The following is a description of a gene set: studied in species Mus musculus Mouse Gene Set: GOBP_ACTIVATION_OF_PHOSPHOLIPASE_A2_ACTIVITY Any process that initiates the activity of the inactive enzyme phospholipase A2., and this is the list of marker genes: Ang2, Ang6, Ang, Ang5, Ang4